Given this list of marker genes DLD (dihydrolipoamide dehydrogenase), KGD4, OGDH, DLST, here is a description of the gene set: Reactome Pathway: OGDH complex synthesizes succinyl-CoA from 2-OG The mitochondrial alpha-oxoglutarate dehydrogenase complex (αOGDH, αKGDH, OGDHC) catalyzes the reaction of 2-oxoglutarate (2OG), CoASH, and NAD+ to form succinyl-CoA, CO2, and NADH. The enzyme complex ("metabolon") contains multiple copies of three different proteins, E1 (OGDH), E2 (DLST), and E3 (DLD), each with distinct catalytic activities. Specifically, it is composed of a core of 24 E2 subunits exhibiting octahedral symmetry. To these subunits are bound up to six E1 dimers and to each of these is bound an E3 dimer and to an adaptive MRPS36 unit. The reaction starts with the oxidative decarboxylation of 2OG catalyzed by E1alpha and beta (alpha ketoglutarate dehydrogenase). Lipoamide cofactor associated with E2 is reduced at the same time. Next, the succinyl group derived from alpha ketoglutarate is transferred to coenzyme A in two steps catalyzed by E2 (dihydrolipolyl transacetylase). Finally, the oxidized form of lipoamide is regenerated and electrons are transferred to NAD+ in two steps catalyzed by E3 (dihydrolipoyl dehydrogenase). The biochemical details of this reaction have been worked out first with alpha ketoglutarate dehydrogenase complex and subunits purified from bovine tissue.<br><br>Generation of reactive oxygen species by OGDHC is a major source of mitochondrial oxidative stress under certain pathological conditions. species: Homo sapiens part of: Citric acid cycle (TCA cycle)